Given this list of marker genes FCER1G, FCGR2B, FCGR1A, C3 (NCBI Gene Id 12266), HLA-E, here is a description of the gene set: Human Gene Set: GOBP_REGULATION_OF_TYPE_II_HYPERSENSITIVITY Any process that modulates the frequency, rate, or extent of type II hypersensitivity. species: Homo sapiens